Given this list of marker genes Uqcc2, Rpusd4, Mpv17l2, Ngrn, Trmt10c, Rpusd3, C1qbp, Cdk5rap1, Trub2, Mrps27, Fastkd3, Fastkd2, Rcc1l, Mettl8 (methyltransferase 8, methylcytidine), Rmnd1, Coa3, Nsun4, here is a description of the gene set: Any process that activates or increases the frequency, rate or extent of the chemical reactions and pathways resulting in the formation of proteins by the translation of mRNA in a mitochondrion. studied in species Mus musculus Mouse Gene Set: GOBP_POSITIVE_REGULATION_OF_MITOCHONDRIAL_TRANSLATION